Given this list of marker genes SLITRK3, HOXD12, HBZ, TFAP2B (transcription factor AP-2 beta), TBX5, ELOVL3, KCNIP1, PHOX2B, PCDHB12, HOXD8, KCNS1, PCDHB16, ADCYAP1, PCDHB18P, SLC15A3, MPPED1, NR2F2, PCDHA3, TDRD1, HOXA3 (homeobox A3), PCDHB7, NR2F1, HOXD4, DCC, KCND3, NTM, NETO1, PCDHB15, PCDHA2, PRDM8, INSRR, ALOX12B, ZNF804A, PCDHB14, LYPD4, CACNA1E, OTOP3, ARX, TAL1, DEUP1, here is a description of the gene set: Human Gene Set: MIKKELSEN_ES_HCP_WITH_H3K27ME3 Genes with high-CpG-density promoters (HCP) bearing histone H3 K27 trimethylation mark (H327me3) in embryonic stem cells (ES). We report the application of single-molecule-based sequencing technology for high-throughput profiling of histone modifications in mammalian cells. By obtaining over four billion bases of sequence from chromatin immunoprecipitated DNA, we generated genome-wide chromatin-state maps of mouse embryonic stem cells, neural progenitor cells and embryonic fibroblasts. We find that lysine 4 and lysine 27 trimethylation effectively discriminates genes that are expressed, poised for expression, or stably repressed, and therefore reflect cell state and lineage potential. Lysine 36 trimethylation marks primary coding and non-coding transcripts, facilitating gene annotation. Trimethylation of lysine 9 and lysine 20 is detected at satellite, telomeric and active long-terminal repeats, and can spread into proximal unique sequences. Lysine 4 and lysine 9 trimethylation marks imprinting control regions. Finally, we show that chromatin state can be read in an allele-specific manner by using single nucleotide polymorphisms. This study provides a framework for the application of comprehensive chromatin profiling towards characterization of diverse mammalian cell populations. species: Mus musculus from publication Mikkelsen TS, Ku M, Jaffe DB, Issac B, Lieberman E, Giannoukos G, Alvarez P, Brockman W, Kim TK, Koche RP, Lee W, Mendenhall E, O'Donovan A, Presser A, Russ C, Xie X, Meissner A, Wernig M, Jaenisch R, Nusbaum C, Lander ES, Bernstein BE (PMID 17603471)